Given this list of marker genes SLC24A5, here is a description of the gene set: Reactome Pathway: Defective SLC24A5 causes oculocutaneous albinism 6 (OCA6) Five members of the NCKX (SLC24) family are all able to exchange one Ca2+ and one K+ for four Na+. SLC24A5 (NCKX5, located on the trans-Golgi membrane) is the prediminant K+-dependent Na+/Ca2+ exchanger in melanocytes and is one of a handful of genes thought to play a role in determining human skin colour. Defects in SLC24A5 can cause oculocutaneous albinism 6 (OCA6; MIM:113750), a disorder characterised by a reduction or complete loss of melanin in the skin, hair and eyes. Patients with this condition show accompanied eye symptoms (Kamaraj & Purohit 2014, Morice-Picard et al. 2014). studied in species Homo sapiens part of: SLC transporter disorders